Given this list of marker genes CX3CR1, CEND1, CDK5R2, ARCN1, ATP6AP2, RERE, CDK5R1, here is a description of the gene set: A developmental process, independent of morphogenetic (shape) change, that is required for the central nervous system to attain its fully functional state. The central nervous system is the core nervous system that serves an integrating and coordinating function. In vertebrates it consists of the brain and spinal cord. In those invertebrates with a central nervous system it typically consists of a brain, cerebral ganglia and a nerve cord. Human Gene Set: GOBP_CENTRAL_NERVOUS_SYSTEM_MATURATION studied in species Homo sapiens